The following is a description of a gene set: from publication Chen Y, Wang X (PMID 31504780) Genes predicted to be targets of miRBase v22 microRNA hsa-miR-148b-5p in miRDB v6.0 with MirTarget v4 prediction scores > 80 (high confidence targets). Human Gene Set: MIR148B_5P studied in species Homo sapiens, and this is the list of marker genes: SLAIN2, CD69, NAA15, ELOVL2, LIMS1, KIAA1217, GJA1 (NCBI Gene Id 7953), TCP11L2, ERP44, KICS2, DSEL, TCEAL1, CHMP1A, BRWD1, NFAT5, C1orf74, ZC3H14, SPHKAP, ANKRD28, HMGCS1, GUCY1A2, NHLH2 (nescient helix-loop-helix 2), ETS1, PLCL1 (phospholipase C like 1 (inactive)), DCUN1D5 (defective in cullin neddylation 1 domain containing 5), RNF13, KCNIP1, TBCEL, IVNS1ABP, TMEM25, CLEC1A (NCBI Gene Id 51267), ALG14, SMAD4, BNIP2, FOXO3, SHANK2, CRIPTO (NCBI Gene Id 6997), TENM1, MAN2B2, UHMK1, AP5M1, ZC3HAV1, TMED4, ZMAT3, UGCG, CLEC5A, FMO3, SATB2, KATNBL1 (katanin regulatory subunit B1 like 1), CFH, UBE3A, PSME3IP1, CUL4B, UBE2QL1, UBL3, ZNF704, PGM3, LRP2BP, RGS2, AHSA2P, SLC18A2, FAM20B, LRRC58, ZNF350, TUT7 (NCBI Gene Id 79670), CDCP2, PLEKHA1, ZBTB20, SNRPD3, BAHD1, KDM2B, PRRX1, CFHR1, BACH2, DESI2, ATP6V1C2, CLEC2B, DLST, C6orf62, SGO1, JAZF1